Given this list of marker genes Rnf41, Slc25a44, Atp13a2, Klhdc9, Calcoco2 (NCBI Gene Id 97692), Zfp697, Tor2a, Ggps1, Blzf1, Anks1, Reep1, Pigv, Ncl, Trp53bp1, Mau2, Cdk16, Trpm1 (NCBI Gene Id 244027), Sema4b, Mboat7, Gfpt1, Tfcp2l1, Grik3, Magi1, Rmi1, Krt222, Insig1, Crebl2 (cAMP responsive element binding protein-like 2), Nfxl1, Nup210, Gpr151, Nphp1, Fam210b, Nefm, Ccdc25, Rap2c (NCBI Gene Id 72065), Zfp980, Bco1, Ntsr1, Lmtk2, Polr3d, Top1, Prss44, 3110082J24Rik, Tmem245, Fgf11, Avl9, Tcf7, Zfp981, Mrc2, Samd4b, Vstm4, Amz1, Tmem267, Gad1, Stradb, Iffo2, 2810459M11Rik, Calcr, Mrpl1, Tmem70, Zfp820, Dagla, Matr3 (matrin 3), Laptm4b, Pik3cg, Igfbp4, Rasal1, 2510009E07Rik, Pgap4 (NCBI Gene Id 77263), Trim66, Tmem161b, Ago4, Rbm3, Nlrp6, Sting1, N4bp1, Mbd6, Mboat1, Bhlhe22, Abcb9, Dock3, Nemp1, Gfer, Slc16a2, Snap91, Eif4g2, Klrb1a, Ago3, Polr1e, Il1r1, Kcnip1, Rnf138, Bmpr2, Rap1a, Pnoc, Otud5, Zng1, Kctd21 (potassium channel tetramerisation domain containing 21), Tmem164, Clns1a, Rsad1, Mrpl45, Mxi1, Fyb2, Dhx33, Luc7l, Nav2, Per1, Atad2b, Skida1, Btaf1, Oxtr, Pskh1, Xpo7, Tmed8, Dlgap4, Agps, Tmem121b, Cers3, Zfp947, Plcl2, Aldh5a1, Plxna3, Tpmt, Rc3h2, Als2, Ttc17, Zfp942, Zcchc14, Camk2b, Stx5a, H2ax, Chd5, Gal3st3, Tceanc2, Rnf2, Mapk14, 9930012K11Rik, Klf8, Brd8, Chmp1b2, Cnot6, Mix23, Sstr1, Rmi2, C1qtnf1, Dmrtb1, Dgkk, Vgll3, Map6d1, Snhg11, Dpp10, Mrpl11, Foxred2, Zfp654, Appl2, Gorab, Pdgfra, Clcn3, Dyrk2, Saysd1, Smagp (NCBI Gene Id 207818), Lhpp, Kbtbd6, Zfp975 (zinc finger protein 975), Crat, Wnt8b, Sesn1 (sestrin 1, NCBI Gene Id 68538), Ark2c, B3gnt5, Tmem151a, Rasa1, Cdh7, Lsamp, Rex2, Zfp446, Kbtbd13 (NCBI Gene Id 74492), Rps15a, Cited4, Slc25a25, Depdc5, Ptger4 (prostaglandin E receptor 4 (subtype EP4)), Zbtb37, Snn, Sdf2, Fam78b, Mecp2, Mia3, Dlc1, Lrsam1, Rala, Med13, Sart1, Tada2b, Prdm1, Klk10, Ebf2, Add2, Zfp68, Zxdc (ZXD family zinc finger C), Spast, Ipcef1, Apob, Kcnb1, Mydgf, Sema4a, Zxdb, Sncaip, Pla2g4e, Hnf1b, Med8, Tasp1, Nadk2, Fst, Calhm4, Zfp811, Nlk, G6pdx, Arid5a, Fsd1l, Ptprf, Kptn, Cmtm4, Agpat1, Amotl2, Pigm, Zswim7, Rubcn, Zfp600, Kcnk2, Lmbr1l, Pde1a, Diaph1, Stc2, Dmtn, Hspb7, Ranbp10, Gal3st2c, Gbx2, Rap1b, Plod2, Pkdcc, Entpd6 (ectonucleoside triphosphate diphosphohydrolase 6), Ppp1r16b, Spon1, Nrp2, Ndst1, Taok1, Dusp8, Tspan14, Neurod1, Cdkn1b, Mmgt2, Bcl2l11 (NCBI Gene Id 76339), Grip1, Apba1, Gnao1, B4gat1 (beta-1,4-glucuronyltransferase 1), Cd300a, Rapgef2, Midn, Rab8a, Tbc1d24, Kif3b, Pml, Scml2, Dusp16, Per2, Cyb561d1, Sphkap, Klhl1, Abhd13, Ugcg, Sptlc2 (serine palmitoyltransferase, long chain base subunit 2), Gm11545, Vav2, Ube2k, Nova2, here is a description of the gene set: Genes predicted to be targets of miRBase v22 microRNA mmu_miR_5124b in miRDB v6.0 with MirTarget v4 prediction scores > 80 (high confidence targets). species: Mus musculus Mouse Gene Set: MIR_5124B from publication Chen Y, Wang X (PMID 31504780)